Given this list of marker genes Nup153, Nup54, Seh1l, Tmem170, Ndc1, Fxr1, Pom121, Rtn4, Tpr, Nup107, Nup133, Nup35, Nup205, Ahctf1, Nup98, Nup93, here is a description of the gene set: Mouse Gene Set: GOBP_NUCLEAR_PORE_ORGANIZATION species: Mus musculus A process that is carried out at the cellular level which results in the assembly, arrangement of constituent parts, or disassembly of the nuclear pore.